The following is a description of a gene set: Human Gene Set: HP_CLOVERLEAF_SKULL species: Homo sapiens Trilobar skull configuration when viewed from the front or behind. Cloverleaf skull, and this is the list of marker genes: POR, FGFR1, MEGF8, EXTL3, RAB23, FGFR2, WDR35, FGFR3